The following is a description of a gene set: Human Gene Set: PID_ARF6_TRAFFICKING_PATHWAY species: Homo sapiens Arf6 trafficking events from publication Schaefer CF, Anthony K, Krupa S, Buchoff J, Day M, Hannay T, Buetow KH (PMID 18832364), and this is the list of marker genes: CDH1, CTNNB1, INS, DNM2, CPE, CLTC, ITGA6, EXOC1, PLD1, ITGA5, EXOC6, ITGA11, EXOC5, ITGA9, SLC2A4 (solute carrier family 2 member 4), ITGA7, ITGA4, ITGA1, ITGB1, EXOC7, EDNRB, VAMP3, CTNNA1, MAPK8IP3, EXOC4, ITGA3, EXOC2, ARF6, IL2RA, ITGAV, TSHR, NME1, PLD2, ADRB2, ITGA2, AVPR2, EXOC3, AGTR1, ITGA8, ASAP2, KLC1, ITGA10, RALA, ACAP1, SPAG9, PIP5K1C (NCBI Gene Id 23396), SCAMP2, CTNND1, BIN1